Given this list of marker genes PTS, NGLY1 (N-glycanase 1), TSPOAP1, SLC6A3, TH, GCH1, IMPDH2, DDC (NCBI Gene Id 9492), NR4A2, PNPO, here is a description of the gene set: Abnormal CSF homovanillic acid concentration species: Homo sapiens Any deviation from the normal concentration of homovanillic acid (HVA) in the cerebrospinal fluid. HVA is a metabolite of dopamine. Human Gene Set: HP_ABNORMAL_CSF_HOMOVANILLIC_ACID_CONCENTRATION